The following is a description of a gene set: Reactome Pathway: Erythropoietin activates Phospholipase C gamma (PLCG) studied in species Homo sapiens PLCG1 (Phospholipase C gamma1) or PLCG2 bound to the activated EPOR is phosphorylated on tyrosine residues by the kinase LYN. PLCG1 and PLCG2 produce inositol 1,4,5-trisphosphate which then activates calcium signaling, and diacylglycerol (DAG) which then activates protein kinase C (PKC). part of: Signaling by Erythropoietin, and this is the list of marker genes: PLCG1, EPO, LYN, JAK2, IRS2, EPOR, PLCG2